Given this list of marker genes Maged1, Gzf1 (NCBI Gene Id 74533), BC028528, Tmem59l, Hnf1b, Shh, Sox8, Hoxa11, Pou3f3, Mtss1, Col4a1, Lhx1, Gli3, Wnt2b, Cited2, Wnt7b, Lama5, Npnt, Stat1, Pspn, Lzts2, Agtr1b, Umod, Dlg1, Cited1, Hs3st3a1, Wnt11, Irx1, Six2, Hs3st3b1, Eya1, Foxd1, Aqp11, Sox9, Six4, Mef2c, Jag1, Hoxd11, Dchs1, Pax8, Pax2, Notch2, Wt1, Agtr2 (angiotensin II receptor, type 2), Klhl3, Slc22a6, Ctnnbip1, Ctns, Kif26b, Bcl2, Tgfb1, Wnt1, Cd24a, Hes1, Prom1, Acat1, Hs2st1, Pkd1, Tfap2b, Lif, Pbx1, Bmp4, Bmp2, Fmn1, Irx3, Ptch1 (NCBI Gene Id 77214), Pkd2, Dll1, Wnt9b, Wnk4, Heyl, Hey1, Abcc2, Osr1, Notch1, Greb1l, Gpc3, Timeless, Gata3, Wwtr1, Smad4, Commd5, Fgf2 (fibroblast growth factor 2), Vegfa, Mir216a, Cd44, Adamts16, Calb1 (NCBI Gene Id 12307), Ctnnb1, Smo, Hes5, Wnt4, Ttc8 (NCBI Gene Id 76260), Nog, Lgr4, Irx2, Mir216b, Aqp1, Tacstd2, Hdac5, Agtr1a, Mir217, Pgf, Grem1, Six1, Hoxb7, Dspp, Myc, Wnt6, Tcf21, Fat4, Yap1, Prickle1, Lgr5, Sall1, Slc22a1, Fgf1 (fibroblast growth factor 1), Ilk, Gdnf, Agt, Fgf8, here is a description of the gene set: Mouse Gene Set: GOBP_RENAL_TUBULE_DEVELOPMENT species: Mus musculus The progression of the renal tubule over time from its formation to the mature form. A renal tubule is a tube that filters, re-absorbs and secretes substances to rid an organism of waste and to play a role in fluid homeostasis.